The following is a description of a gene set: Human Gene Set: MCBRYAN_PUBERTAL_BREAST_6_7WK_DN Genes down-regulated during pubertal mammary gland development between week 6 and 7. from publication McBryan J, Howlin J, Kenny PA, Shioda T, Martin F (PMID 17486082) Expression microarray analysis identified over genes regulated during puberty in the mouse mammary gland. Most prominent were genes whose expression increased in parallel with pubertal development and remained high thereafter. Members of the Wnt, transforming growth factor-beta and oestrogen-signalling pathways were significantly overrepresented. Comparison to expression data from CITED1 knockout mice identified a subset of oestrogen-responsive genes displaying altered expression in the absence of CITED1. Included in this subset are stanniocalcin2 (Stc2) and amphiregulin (Areg). Chromatin immunoprecipitation revealed that ERalpha binds to oestrogen response elements in both the Stc2 and Areg genes in the mammary gland during puberty. Additionally, CITED1 and ERalpha localize to the same epithelial cells of the pubertal mammary gland, supporting a role for interaction of these two proteins during normal development. In a human breast cancer data set, expression of Stc2, Areg and CITED1 parallel that of ERalpha. Similar to ERalpha, CITED1 expression correlates with good outcome in breast cancer, implying that potential maintenance of the ERalpha-CITED1 co-regulated signalling pathway in breast tumours can indicate good prognosis. species: Mus musculus, and this is the list of marker genes: BLTP3A, SFRP1, PLOD2, IFIT3, MAL, LSM14B, NR1D1, PDLIM4, IRAK1, SLC4A4, MYH11, ATP5MK, CDCA3, ALAS2, CCNB1, WFDC21P, TIMP1, SERPINB11, HMGB2, DUSP6, TNC, SLPI, LY6D, TOB2, ACSM3, VCAN, CNN1, CDC20 (NCBI Gene Id 991), SERPINA3, EHF, MT1X, UNC50 (unc-50 inner nuclear membrane RNA binding protein), KIF22, TAGLN, F2R, HCAR2, CDK1, PTTG1, ACTG2, SFXN1, DSP, TNFRSF12A, IL33, PLA2G7, ST6GALNAC5, ACTA2, TGIF1, CISD1, APOD, CAP1, MKI67, BCL6, SDC1, CCNL2, PER3, EPS8, CA4, UPK3A, IFT57, PAM, H19, BPGM, EGR2, SNRNP27, S100A8, MBP, RNF149, SLC1A3, FBLIM1, UGT8, FAAP20, RPS10, PALLD, AREG, UTRN, MPZ, IGFBP2, F3, UBE2C